Given this list of marker genes AZI2, PIP4K2B, TRAFD1, CMTM4, FBXL20, USP13, FZR1, ZDHHC3, DNAJC4, POMGNT2, SIN3A, ASH1L, RMND5B, SMO, PEX11B, TADA2B, KCTD10, SEMA4F, CCDC3, DCUN1D3, URGCP (upregulator of cell proliferation), MMP16, INVS, TMEM138, C1QTNF6, MKS1, VPS53, GGT7, KPNA6, WDR6, TMEM254, KRT85, DHRS11, ST6GALNAC4, SMG5, PRDM4, POLR2M, EDNRA, VCP, AP2A1, MIER2, CNPPD1, ADD2, F2, ARL2, TRPV6, PPIE (NCBI Gene Id 10450), CIC, USF3, COG5, SNX33, KLHL17, GIGYF1, COPS7A, SPPL2B, STAT5B, RHOD, TUT1, DHX37, SEC24A, here is a description of the gene set: Neighborhood of SMO smoothened homolog (Drosophila) in the GCM expression compendium Human Gene Set: GCM_SMO species: Homo sapiens Neighborhood of SMO